The following is a description of a gene set: Genes up-regulated in the in vitro follicular dendritic cells from peripheral lymph nodes: unstimulated versus Pam2CSK4 (96h). Germinal centers (GCs) are clusters of activated B cells built on stromal cells known as follicular dendritic cells (FDCs). In the Peyer’s patches (PPs), GCs are chronically induced by bacteria and are the major sites for generation of gut IgA immune responses. Whether FDCs directly contribute to the IgA production in PP GCs is unknown. To investigate the role FDCs in gut immune system, we examined comprehensive gene profiles of FDCs purified from PPs or perypheral lymph nodes (pLNs) with or without immunization. We also tried to reconstitute the PP FDC signature in vitro by pulsed or continuous stimulation of pLN FDCs through TLRs, RARs or simultaneously through TLRs and RARs. from publication Suzuki K, Maruya M, Kawamoto S, Sitnik K, Kitamura H, Agace WW, Fagarasan S (PMID 20643338) species: Homo sapiens Human Gene Set: GSE19401_UNSTIM_VS_PAM2CSK4_STIM_FOLLICULAR_DC_UP, and this is the list of marker genes: DKK1 (NCBI Gene Id 22943), UBE2V2, INSIG2, ZNF41, SERPINB2, MMP14, POU2F1, RFTN1, INPP5K, ZNF391, PPP1R13B, MAP2K3, TDRD7, PTH, ARF6, SOX1, IL1B (NCBI Gene Id 3553), ASCC3, CCL3, CAV3 (NCBI Gene Id 859), VCL, BRD3OS, XRCC3, RRN3P1, NRTN, GNB5, CCL20, KIAA0586, GLE1, MUC1, KRR1, DUSP5, TNFAIP8, KLHL21, TP53BP1, SRD5A1, ZNF85, GCK, GALNT18, RNF19B, UCKL1, SEMA6C, SOS1, TIMELESS, ZNF345, IRS2, PCNX1, SLC27A2, EXO1, CSRNP2, MKLN1 (muskelin 1), PURA, SLC26A4, FGF6, MAP3K3, ACVR2B, KLHL23, TM4SF4, NXPH4, RPS6KA5, PCNT, CDC42EP3, COG2, CPD, TEX41, ITGA1, BCAP29, TRAF3, FOXO3, NOVA2, CYP17A1, CCL7, UST, ZNF460, CLIP3, MXD1, BMS1, REG3A, HSD17B6, ERP44, SRSF10, ZFP36, CENPS, WDR47 (NCBI Gene Id 22911), ING3, CASK, PFKFB4, H2AC6, SPARCL1, H2AX, RIPK2, EPM2AIP1, KARS1, EIF1AX (eukaryotic translation initiation factor 1A X-linked), ACTC1, WNT8B, TAF6, WDR13, NF1, CSNK1E, PLK3, WNT11, SBNO2, PPP2R2A, LIMK2, IGSF3, LIAS, DNMBP, LPIN2, FEM1C, MAMLD1, SART3, IL6, FGFR4, TENT4A, KLF1, GABPB1, CDH15, NR2C2, MMP17, SLC25A42, EOLA1-DT, USP34, SBF1, BRD4, LRRC14, UBE2B, SIK2, DHX8, PLCE1, NDC80, STX11, SHOX, ADORA2A, AK4, NCOR2, GRK6, PTGS2, H2AC15, CPSF4, SENP5, IGF1R, IPO9, BBC3 (BCL2 binding component 3), MCM7, ZBTB7B, SNX13, BCL2, TPM1, SCN7A, THOC5, PRPF3, POLG2, TNFRSF10D, RFC3, IER2, GPSM2, RNF103, FAM20B, CHD1, EFNB2, COL4A1 (NCBI Gene Id 1282), IAPP, HGS, GUCY1A1, FABP1, ENTPD4, LIG1 (DNA ligase 1), GALR2, TOB2, H2AC11, TRAF1, HAPLN1, ZRSR2, CACNB4, FGD1, TRIM23 (tripartite motif containing 23), ATP11B, SRPK1, ZKSCAN1, ZC3H11A, PDLIM3, CCL4, JAK1, CRY2, HTR7P1, TBCC, ZNF273, CACTIN (cactin, spliceosome C complex subunit), CDC42EP2, FAM107A, RAB27B, BAHD1 (NCBI Gene Id 22893), RAB40C, FPGS, PPARA, HIC2